The following is a description of a gene set: Mouse Gene Set: GOBP_PROTEIN_DEGLYCOSYLATION species: Mus musculus The removal of sugar residues from a glycosylated protein., and this is the list of marker genes: Edem3, Park7, Fktn, Aga, Engase, Edem1, Oga, Edem2, Large1, Man1a